The following is a description of a gene set: Genes in the cancer module 95. Human Gene Set: MODULE_95 species: Homo sapiens, and this is the list of marker genes: KCNS2, HRAS, ADARB2, GALNT13, NFATC4, FSTL4, TDRKH, RBMS1 (RNA binding motif single stranded interacting protein 1), KMT5C, MYO16, FMO4, DIS3 (DIS3 homolog, exosome endoribonuclease and 3'-5' exoribonuclease), RASL12, AKAP4, CLDN14, ETAA1, PLAAT5, HOXB8, SLC35A5, BORCS8-MEF2B, URB1-AS1, SERPINB5, GNGT2, BLOC1S6, SOX1 (NCBI Gene Id 6656), BMPR1B (NCBI Gene Id 658), RBM42, FMNL1, FETUB, WDR46, BCAP29, POPDC2, SLC25A28, DAO, MAPK9, HCRTR1, R3HDM2, KIAA0319, AKT1, N6AMT1, NCF1C, DOP1B, LUM, HOXB13, EPCIP, DYNC2I1, ZNF79, PCNP, ICOS, UST, ZBTB25, ARHGAP45, TTC22 (tetratricopeptide repeat domain 22), C2CD3, TMEM106C, EGF, TMCC3, MCPH1, EFCC1, TULP1, TYMP, VWF, KCNMB3, ZNF408, FOXF2, IL33, P2RX7, CPA6, ACYP2, SYN1, STYXL2, POLE2, EPS8L3, TRPA1, CRB1, PPAT, SPINK1, KCNV1, MYCN, SLCO1A2, GRIP2, GPR182, CHFR, OAS3, RPS2, NLRX1, RFX7, ZNF333, PHKG1, HCG4, CNDP1, ADORA1, PGS1, RGS14, BCAS4 (breast carcinoma amplified sequence 4), KIF3B, CDH10, MYL2, GABRA2, GALNT15, STXBP1, TMA7, FAHD1, SYT4, GYPB (NCBI Gene Id 2994), CDO1, PER1, TCIM, NALCN, NXPE4, MYT1L, PSCA, SGSH (N-sulfoglucosamine sulfohydrolase), ROBO4, ANKRD26, KCNJ4, POLR3B, KCNB1 (NCBI Gene Id 3745), CREB3L1, USP6, FBXL5, WDR75, PPP1R13B, SHISA3, DDA1, SYNGAP1, NOX4, ARSB, BTC, RP2, NPC1L1, HTR2B (5-hydroxytryptamine receptor 2B), CAPNS2 (NCBI Gene Id 92942), TP53, INMT, CABP5, CD99L2, ZNF649, DYDC2, TMEM200A, ARMCX5, COL4A4, DMXL2, ZNF343, DGCR5, SLC6A16, TBL3, SEMG1 (NCBI Gene Id 6406), CRYGA, SLC15A2, DNAJC30, OTOF, MRPS31, NDC80, CCS, SNX10, EMSY, CDC14A, MS4A5 (membrane spanning 4-domains A5), C22orf31, TRAPPC6A, P2RY6, SMPD2, BSCL2, SRP54, MYBPH, HMGA1 (NCBI Gene Id 3159), PRSS3, RBM15, SAGE1, ENTREP1, SLC22A2, TCTN1, EMP2, MRGBP, NXT2, PPDPF, LRRC37A, SLC39A7, TMEM30A, DMWD, AHSG, CPED1, TAFA5, PLCD1, SIAH1, SLURP1, HMBS, FLNC, TLL2, UPB1, SLC52A1, DDIT4, TINCR, LY6G6C, MYO15B, TOR2A, HSPB2, TMEM231, NUSAP1, SKAP2, SERPINE1, DSG2, TDRD7, SAYSD1, CAPZA2, SEMA6C, UPF3B, PSG6, ORC6, TOMM22, ZNF211, HCRTR2, PCDHGB6, RHOT1, FAM135B, PHYHIP, TGM7, CD72, TBXT, ADPRHL1, RHO, HDAC9, CIRBP, RIPPLY1, BCAS1, ASB12, FAM234B, ZNF214, APOBEC1, AK1, GLT8D2, MKI67, PLPPR4, ERMN, SUSD4, SIPA1L2, TXNIP, BEND5, CD5L, KLHL25, MCOLN3, BPESC1, NTRK3, RAB3C, DLX3, LINC01549, FOXJ1, ART3, CELA3A, DNAJC22, DLGAP2, TERT, TLR7, SPZ1, GABRA6, SEZ6L2, TENT5B, MXRA8, SFTPD, SLC26A3, RANBP3, SEMA6B, STX1B, DOCK1, KLHL3, DGKI, H1-2, BBOX1, RGS8 (regulator of G protein signaling 8), TLX2, TEX14, PALLD, EGR1, PDE5A, ITIH5, VIL1, ZNF365, TGM4, SLC7A9, PRRG3, AJAP1, PIMREG, CELSR3, INVS, PERP, TAF4B, HIC2, TTI1, SPDEF, PGAP3, KCNJ11, ZNF195, VAMP5, EDN2, KLK4, MED15, MYO3A, EIF4EBP1, C4orf17, PURG, CASR, FGF5, GRP, SCGB3A2, REG1B, ARHGEF25, SERGEF, UBE2C, ADAMTS10, CDKN2B, CYP39A1, OSTC, OR2I1P, DDX39B, TTN, MUCL1, DNAJC10, XPNPEP2, NXPH4, CCL26, IL1A, THAP10, PTPRR, DNAJC28, DDN, TBX5, GPC5, INPP1, RGS16, TGM3, NPVF, MAP1A, SPP2, XKR4, SLC7A10, ADAMTS7, PCDHB15, NOTCH1, LILRA1, TMEM45A, EIF3H, CYP2E1, FASTKD1, SLC2A9, PLA2R1, MRPL50, MAPRE1, TSHB, ACTN1, NECTIN2, SCAPER, SNURF, BSN, FCMR, ADAT3, RAB27A, ZNF175, NRP1, ERO1B, EPB41L4A, PGLYRP4, NAT8, CDX1, PRKAG3, STK32B, CTPS2 (NCBI Gene Id 95807), REM2, METTL16, GRB14, BHMT, VAMP8, SYNPO2L, H2AC8, CLEC3A, TMED5, WNT4, MAPK15, HIF3A (hypoxia inducible factor 3 subunit alpha), COBL, PRDM10, EEF1G, SAMHD1, KLK11, SPACA9, NLRP12, IL17B, STK25, ST6GALNAC1, SANBR, VWA1, CFAP61, PLXDC2, ELAPOR1, GIMAP5, MEGF11, ID2B, CSMD3, PEX11B, KRT10, ZNF462, SNX8, LRRC8D, ZNF821, PRKACB, RETREG2, TMEM40, RAB7B (RAB7B, member RAS oncogene family), GPRC5C, BICD1, KLHL32, DSG1, C8orf34, LINC00839, ANO10, TLX1, SPO11, CCHCR1, CCDC65, P2RX3, SH3RF1, AVIL, RAD21, PAX2 (paired box 2), PELI2, GRB2, GTF3C4, SRPK3, ANO3, CA4, ANKZF1, NDUFA2, ZCCHC4, SLITRK5, DPM3, TOP6BL, NRXN1, GCM2, FPR2, SH3TC1, H4C3, TSPAN8, IBSP, GPC4, CHL1, TNNT1, DHRS3, LAMTOR5, CPA1, OR51E2, NCF2, PFAS, STK38L, NFATC2IP, FEZ2, GPN2, ZNF777, DSCAM, MPP4, CELA2A, DENND3, KCNA4, POF1B, STAR, DRC7, HOOK1, GTF3C1, CECR2, ACBD6, HTRA2, ADAMTS12, RAD51AP1, MCF2L, KLRG1, ITLN2, HAS2, CACNB4, PCA3, ALKBH3, COL20A1, ADAMTSL1, SOHLH2, DNMT3B, RBM23, STX11, RIPK4, HPCAL1, SLC22A8, ACE2, NOS2, IFT140, PSD2, SAG, ATP10D, TPK1, AQP2, BEST3, PABPC3, PPFIA2, TMC5, BORCS6, PLXNA1, MYO15A, TXNDC5, FDX2, DPF3, ADAM6, P2RY1 (NCBI Gene Id 90963), GPR35, ATP2B3, IFFO1, EYA1, PRR5L, CACNG4, FAM199X, FXYD2, TOX2, GIT2, STC2, NTRK2, GSN, IRF4 (NCBI Gene Id 4592, interferon regulatory factor 4), CNBD2, SPRTN, ASAP3, PBK, TBC1D8B, STRA6, OPHN1, RBM17, SLC66A1LP, ESPL1, BPIFA1, ANKRD27 (NCBI Gene Id 84079), RTTN, VPS45, FBXO5, CPNE1, TXNDC12, FKTN, KCNH3, OTX2, THSD7A, PLA2G12B, ZDBF2, ADAMTS5 (NCBI Gene Id 11096), BAAT (bile acid-CoA:amino acid N-acyltransferase), TIRAP, AKR7A3, SRXN1, UBE2E1 (ubiquitin conjugating enzyme E2 E1), TOX4, S1PR5, ICMT, IFTAP, GRIK2, BTBD8, FAM83D, WNT10B